The following is a description of a gene set: from publication Yevshin I, Sharipov R, Kolmykov S, Kondrakhin Y, Kolpakov F (PMID 30445619) Human Gene Set: H1_6_TARGET_GENES species: Homo sapiens Genes containing one or more binding sites for (H1-6) in their promoter regions (TSS -1000,+100 bp) as identified by GTRD version 20.06 ChIP-seq harmonization., and this is the list of marker genes: DUSP6, URB2, TULP3, TBXT, SMIM8, TP53BP2 (tumor protein p53 binding protein 2), REXO4, OVOL3, THAP12P8, ARFGAP2, PLA2G6, CEP57 (NCBI Gene Id 9702), MIR521-2, CEACAMP2, MORF4L2, ZNF283, GARIN5A, ZNF415, AFAP1L2, ZNF451-AS1, FEZF1-AS1, AFDN, INTS3, RNVU1-21, PPP4R3B, KCNG1, GIT1, CCDC88C, SHKBP1, AP2S1, SLC7A6, INKA2, ALG12, TMEM147, ACBD3, UCP2, LINC01271, ASXL1, ZHX3, SLC9A1, LPIN3, FLCN, FABP5, GMFB, LIG1, CDK13, ZBTB7B, SLC13A3, EIF2D, SLFN13, PLEKHA8P1, RHNO1, ZCCHC4, COQ8A, PEAR1 (platelet endothelial aggregation receptor 1), IPO13, SH3BP5, RHBDD3, GTF3C6, TMEM222, TATDN3, PLK3, MRPL21, HSPD1P19, SLC30A10, NFKBIB, TBC1D17, LYPD4, ARMC8, ZNF524, CEACAM1, RNVU1-23, LAMP1, TFDP3, GSTZ1 (glutathione S-transferase zeta 1), UCMA, ADM5, RNU6-696P, PSG4, RNA5SP472, CNBD2, IGHMBP2, ATP1B1, LHX9 (NCBI Gene Id 56956), EEF1A1, MIR5087, TCP11L2, ACTA1 (NCBI Gene Id 58), CRIP1, CPEB3, RAPGEF1, MT4, PHF2, QPCT, FAM76B, TAB2, SRRM5, FCRLB, PITHD1, TEDC1, COPS7B, FLOT1, ACBD6, SIRT2, PRRC2C, NEK2-DT, ENSG00000258422, CALM1, ARHGEF1, RGS11, RDH13, RMI1, CDHR3, RC3H1-DT, LYPD5, CASKIN2, ZNF813, NUDC, SNRPF, HIGD1AP11, NTRK1, PSMC3, ATXN1, MGAT5B, STX18-AS1, DLST, PAQR6, SSR4, LRRC8A, PTPMT1 (NCBI Gene Id 114971), ADAMTS15 (ADAM metallopeptidase with thrombospondin type 1 motif 15), VRTN, RABAC1 (NCBI Gene Id 10567), SUPT5H, LAMTOR2, PERPP3, PAFAH1B2 (platelet activating factor acetylhydrolase 1b catalytic subunit 2), PHACTR1, NHLH1, NEGR1, SLC2A1-DT, ECI2, DDR1, SELENBP1, RASAL2-AS1, TTC7B, STMN3, SNRPF-DT, NSL1, RBM15, EHHADH, MRPS15, LSM14A, KLK6, KYAT1, ZNF576, ELFN1-AS1, ZBTB45, DNMT3B, TMEM269, C6orf120, SS18L2, NOS1AP, C19orf47, CRYGN, PDE4DIPP6, MARK4, CHD1L, FOS, SGCA, B3GNTL1, TFAP2A, C1orf220, C9orf43, PLSCR1, RNVU1-17, TM4SF18-AS1, RNVU1-3, GMDS, LARP1, CATSPERG, LRRC61, SMARCD3, MIR6504, COX5AP1, CIC, DHX32, CDR2-DT, ANP32E, MAGIX, CYTH2, MPZL1, PPP1R36, NPHS1, BLCAP, PHF5A, ZNF614, ITGAM, MIR4530, CSE1L-DT, CNOT7P2, AKT2, PRKCIP1, PARP12, RRP15, RPS4X, ZBTB46, APLP1, CXorf58, TMEM185B, ATG2B (autophagy related 2B), TM9SF1, NEK2, PRRG2, EGLN2, RPS16, CNTN2, FRG1HP, DNTTIP1, RPL18A, GEMIN7, SYTL2 (NCBI Gene Id 84564), CROCC (NCBI Gene Id 9696), CA11, TNPO1-DT, PRR12, SAPCD1-AS1, KEAP1, PDE6D, IRGQ, MAPDA, MIR5588, NNAT, SRP14-DT, CCN1, WDHD1, INKA2-AS1, SRSF5, EML1, CORO7, ZNF701, ZNF263, FIZ1, FFAR1, CDK9, PIGC, NFKBID, XRN2, LEKR1, HMGB1, PCM1, STARD10, PPP1R12C, FAM133FP, SYTL4, ICA1L, CCDC124, ADAT2, KCNB1, TIPRL (TOR signaling pathway regulator), RPL26, NDUFA6-DT, RTEL1, RNA5S6, SETD3, C1orf56, DCAF5, RNA5SP528, PPP4R3B-DT, TXNDC15, GPBP1, SH2D2A, RPL13, DDHD1-DT, MAPKAPK5-AS1, VPS33A, LETM1P2, FOXM1, HNRNPU, UBE2I, USP40, H1-9P, HSPA9, CD81, C1orf226, ZSCAN18, SNORD68, TPM3P5, DDHD1, ZNF200, RASGRP4, NOSIP, AURKA, LINC01531, MINK1, EMC10, LINC00904, CYP2S1, VCPKMT, GPT, MIR4314, PPP2R5C, EEF1E1, TRMT1, ADCY7, HP1BP3, ZNF302, B4GALT7, VPS11-DT, PABPC4, SCAMP4, PCIF1, SNRNP70, NBPF1, TRUB1, SPG7 (NCBI Gene Id 87549), ITIH3, PTPN21, LNMICC, NAPSA, CCDC88C-DT, EPB41L2, ZSCAN22, POLE3, EPS8L1, HEXIM1, VRK3, HRH3, INO80E, LINC01686 (NCBI Gene Id 284648), EPSTI1, PABPN1P1, IMPDH1P11, ZNF565, ATF5, CA4, COA4, IL4I1, CPNE1, ZNF573, IGSF9, HNRNPK, STX16-NPEPL1, WDR27, MOCS3, TYMSP2, SIGLEC11, TMEM179, KLK3, AIMP1, CCNK, GCNA, FBXO28, HAND2-AS1, RPF1, ZNF180, NOM1, CAPN1-AS1, SELENOW, PAAF1, WFDC3, MROH3P, CMPK1P1, WDR47, TPM3P2, GSE1, IPO9-AS1, TUBG1, ENTPD1-AS1, RGS9BP, DPM1, SNRNP40, PPP1R18, MIR6769B, PROX1 (NCBI Gene Id 5629), SLC1A5, CSTF1 (NCBI Gene Id 1477), SNORD15A, SNHG11, DPY19L3, TMEM147-AS1 (TMEM147 antisense RNA 1), KIF25, MIR4291, FOXQ1, C19orf48P, PPP5C, PRSS27, ECI2-DT, PCK1, GAPDHP64, RNVU1-2A, PDSS1, ATXN7L1, PRELID3B, SRD5A3-AS1, RPS3, SRP14, ZNF146, HOXB-AS3, TEX14BP, FBRS, LFNG, NT5C2, ITPKB, KDM4C, BCAT2, TUFT1, RAB29, ZNF649, ABCD4, GNG4, GMDS-DT, TAF5L, DMAC2, DIO3OS, NDUFV2, PMP22, RBM42, SCAND1, STX16, ECH1, VPS11, NRBP2, CELF1, LINC01838, KLHL8, MAP4K5, USE1, OSBPL2, HSPA6, RNF213, MIR1302-3, FRMD1, LIN9, CCDC175, ACHE, EIF2B2 (NCBI Gene Id 8892), RBM38-AS1, PIGQ, NECTIN2, ZNF222-DT, OTOF, SYCP1, MAPT (microtubule associated protein tau), MTARC2, ZBTB18, ATF3, MPND, ZC3H15, LINC03072, PPOX, LGALS8, NVL, JARID2-DT (NCBI Gene Id 118597839), WAKMAR2, AVPR1A, SLC50A1, CEACAM16-AS1, TBCK, TRA2B, KMT5C, CAPN1, MATCAP2, JARID2, PRKCH, PHF19, ZNF783, HOXA10, MAPKAPK5, ALDH7A1, LRRC37A3, ALKBH3, CEACAM21, ANKRD13B, ZNF780A, CALR, NIT1, LIPE, COX20, VSX1, LINC02918 (NCBI Gene Id 101929609), DYNLRB1, ELOA-AS1, EWSR1, A1BG-AS1, GNA12, ZNF564, ZNF473, TMEM165, NAPA, WASHC4, TMPRSS4, MORF4L2-AS1, ZNF234 (NCBI Gene Id 94536), TTC39A, AURKAIP1 (NCBI Gene Id 54998), CHRNA2, DMRTC2, ACTR3C, UNC119, PEX3, SEC16B, TMPRSS6, TMEM9, CRYBB2P1, PACS1, PACS2, PHLDA1, AMZ2, PROX1-AS1, SELENOOLP, SMOX, ALOX12B, ESYT3, SPTBN4, COL1A1, IQCE, STX18, ANXA4, ZNF570, NEK9, MAP3K10, RTEL1-TNFRSF6B, ZBTB47, SLC2A1, MBNL3, NUP62, AKR1E2, KCNQ2, ZNF181, SLC44A2, ZNF552, SOCS4, ARFIP1, LINC02447, RGL2